The following is a description of a gene set: Any process that stops, prevents, or reduces the frequency, rate or extent of transcription elongation, the extension of an RNA molecule after transcription initiation and promoter clearance by the addition of ribonucleotides catalyzed by a DNA-dependent RNA polymerase. Mouse Gene Set: GOBP_NEGATIVE_REGULATION_OF_DNA_TEMPLATED_TRANSCRIPTION_ELONGATION studied in species Mus musculus, and this is the list of marker genes: Nelfb, Eapp, Parp1, Hexim1, Nelfcd, Zc3h4, Axin1, Supt4b, Nelfe (negative elongation factor complex member E, Rdbp), Recql5, Rnf8, Shh, Rnf168, Sirt6, Supt5, Ezh2, Wdr82, Supt4a, Nelfa, Hnrnpu